Given this list of marker genes OCRL, BBS1, PRKCSH, BMPER, TRIM32, ARL6, LIMK1, PMM2, BBS5, RFC2, BBS4, CEP290, BBS10, LZTFL1 (NCBI Gene Id 54585), GTF2IRD2, JMJD1C, TTC8, DHX16, METTL27, MKKS, IFT27, RREB1, SCAPER, BBS7, WDPCP, NCF1, TMEM270, PEX13, IFT74, VHL, IFT172, DNAJC30, FKBP6 (FKBP prolyl isomerase family member 6 (inactive)), SCLT1, GTF2IRD1, MKS1, VPS37D, BBS12, BBS9, CEP19, EIF4H, PKD2, TSC2, CFAP418, TBX1, FLNB, NOTCH2, TBL2, BUD23, UFD1, TSC1, SALL1, DACT1, GP1BB, COMT, BBIP1, SDCCAG8, COL4A1, NPHP1, BAZ1B (NCBI Gene Id 9031), SEC63, ALG5, ELN, CCND1, SEC24C, GTF2I, CLIP2, ARVCF, HIRA, BBS2, STK11 (NCBI Gene Id 6794), LRP5, STX1A, EXTL3, here is a description of the gene set: The presence of many cysts in the kidney. species: Homo sapiens Multiple renal cysts Human Gene Set: HP_MULTIPLE_RENAL_CYSTS